Given this list of marker genes KCNH5, MAPRE3, ESM1, RIMKLA, FASLG (NCBI Gene Id 356), CLINT1, RASSF5, SHTN1 (shootin 1), HACD4, UBL3, EPAS1, CA12, KCNE3, POLR2G, ARHGEF26, PADI4, MINK1, CALHM6, PARG, OGN, RHAG, DDHD1, VIPR1, AKR1C3, TIGD2, ACVR2A, MX2, IRF9, CMPK2, AHR, UTS2R, USP18, RASGRP1, ENC1, B2M, C11orf86, PCDHB16, GZMB, INTS5, AJUBA, ZFHX3, PEX26, KDM6B, ERMP1, NNT, NAMPT, C9orf152, HLA-B, IKZF3, DCLK1, HOXA1, NDP, NKG7, ZPBP2, ITGB3, SV2C, RELT, SLC2A9, EMX2, SUN2, IL4, NSD3, FAM241A, TRAF6, DSP, MC1R, C3orf18, HAP1, MAP7, UNC79, CD27-AS1, ATP8B1, CAPN15, NXPE2, MYOM2, ZNF471, ARIH2 (NCBI Gene Id 10425), PDPR, PPM1H, COL1A1, BMPER, MYH4, SLC18A2, IFNG, PPP3CC, NCEH1, PARP11, PARP12, PLXDC1 (NCBI Gene Id 57125), KCNK13, RSAD2, ABHD17B, IL1RAPL1, CAMK2N1, PIK3R3, MGST1, PROS1, HAO2 (NCBI Gene Id 51544), PPARGC1A (NCBI Gene Id 10891), BRD3OS, VASH2, PITPNC1 (phosphatidylinositol transfer protein cytoplasmic 1), SHFL, SLC22A9, CACNB1, LITAF, TMPRSS11F, GCGR, TBX21, BACH1, RNF43, SPTLC3 (serine palmitoyltransferase long chain base subunit 3), MPZL2, PLAC8, MBOAT1, RAB4A, MMP13, BNC1, CTPS1, TEX15, RFX7, ARL4C, CFAP20DC, ZCCHC18, ENPP1, ZSCAN21 (NCBI Gene Id 85010), IRF1, KIF21A, MYL1, GPM6B, GJA1, PPP1R16B, ADAM28, CHD3, ARMCX3, LPL, GBP6, SEMA4C (NCBI Gene Id 54910), SFT2D2, HUS1, NR0B2, ST8SIA6, TCEA1, NFRKB (NCBI Gene Id 94689), GBP7, CD1D (NCBI Gene Id 912), LGALS12, EML4, LANCL2, ZFP36L1, CBLN4, HOXB1, CASP3, MTARC1, ERLIN1, HHEX, TTK, INHBC, BEND6, WIF1, P2RX7, AZIN2, BDNF, GBP4, PLCE1, GPAM, ZMAT4, SP110, KRTAP2-4, RAB37, DTX3L, PHF3, ADGRL1, FASTKD3, IRGM, EGR2, MCUB, MFSD14B, SLC13A3, NOL4, PRMT9, FGF13, C6orf136, NEURL1B, HOOK1, MYO6, CNN3, MINDY3, SNTB2, TMEM236, ALX4, HAPLN1, TEX26, TRAPPC10, IL21, PTH, IL10, F2R, HYKK, here is a description of the gene set: from publication Lee Y, Awasthi A, Yosef N, Quintana FJ, Xiao S, Peters A, Wu C, Kleinewietfeld M, Kunder S, Hafler DA, Sobel RA, Regev A, Kuchroo VK (PMID 22961052) Human Gene Set: GSE39820_IL1B_IL6_VS_IL1B_IL6_IL23A_TREATED_CD4_TCELL_UP Genes up-regulated in comparison of untreated CD4 T cells treated with IL1B and IL6 versus those treated with IL1B, IL6 and IL23A. TGF-beta3 produced by developing Th17 cells induces highly pathogenic T cells that are functionally and molecularly distinct from TGF-beta1-induced Th17 cells. The microarray data represent a distinct molecular signature for pathogenic versus non-pathogenic Th17 cells. studied in species Homo sapiens